The following is a description of a gene set: studied in species Mus musculus from publication Chen Y, Wang X (PMID 31504780) Mouse Gene Set: MIR_466G Genes predicted to be targets of miRBase v22 microRNA mmu_miR_466g in miRDB v6.0 with MirTarget v4 prediction scores > 80 (high confidence targets)., and this is the list of marker genes: Fat1, Mbnl2, Csf2ra, Cadm2, Nfya, Neurod6, Arpp19, Sema3e, Ric3, Mrpl15, Exph5, Map2k4, Ctsc, Zc3h7b, Pcdh8, Cand1, Tubgcp4, Zscan4c, Cep97, Scai, Sun1, Slc25a29, Hook1, Xkr4, Cdk14, Tmem202, Bnip3, Aff4, Or12j5, Entpd7, Exd1, Ppp4r2, Fryl, Rassf9 (NCBI Gene Id 260311), Arhgap15, Zscan4d, Spring1, Pld3, Caap1, 1810037I17Rik, Syne3, Eif2s3y, Atp6v1c1, Nfia (NCBI Gene Id 68838), Klk10, P3h1, B3gntl1, Atf3, Zfp937, Ide, Ston2, Rrbp1, Mcl1, Atxn1, Lmod2, Zfp385b, Pygl, Rbms3, Gmnc, Atg4a, Tfdp1, Rhou, Ppp1r15b, Tmem181a, Zcchc14, Sall1, Oas3, Slc25a32, Zfp12, Pde1b, Slc24a2, Celf4 (CUGBP, Elav-like family member 4), Gldn, Psma5, Rapgef4, Ppp1r9a, Notch1, Fosl2, B4galnt2 (NCBI Gene Id 14422), Cep68, Ahr, Amot, Rnf41, Cstf3, Retreg2, Lrp2bp, Yy1, Otud6b, Cryz, Hc, Zfp78, Hnrnpu (NCBI Gene Id 98724), Ctdspl2, Obi1, Trhde, Gata2, Rps6kb1, Clvs2, Srsf7, Mapk10, 2210408I21Rik, Rspo3, Spred1, Rtcb, Enox2, Ugt8a, Klri2 (NCBI Gene Id 320407), Eprs1, Trappc12, Bcor, Hhip, Spaca7b, Nfat5, Map4, Lypla1, Neurod4, Tsga10 (testis specific 10), Kdm6a, Hoxa1, Rab40b, 2210016L21Rik (NCBI Gene Id 72357), Fgf9, Map3k20, Cse1l, Naa16, Crispld1, Galnt4, Trpc5, Muc15, Rps6ka6, Ttc9, Pgap2 (NCBI Gene Id 97348), Raf1, Stxbp5l, Epc1, Tox, Rhob, Idi1, Hsd17b11, Unc50, Naalad2, Zfhx3, Slc39a13, Pwwp2a, Zyg11b, Cul1, Dlg2, Lpp, Dcun1d1, Adgrl2, Dck, E2f3, Adam23, Zcchc24, Prtg (protogenin), Cdc73, Aak1, Ptprn2, Sft2d2, Lix1, Glra2, Nup205, Lin54, Cnot6l, Cpsf6, Flrt2, Gphn, Zfp472 (NCBI Gene Id 224691), AU015228, Polr2b, Odad4, Zfp629, Pml, Cfap97, Rictor, Pdcd10, Ncbp3, Rtn3, Cnr1, Gpr155, Nsd2, Nexn, Klhl4, Nktr, Ppp3cb, Rap1a, Cdhr1, Rad1, Dcun1d4, Enah